The following is a description of a gene set: Any process that decreases the rate or extent of cholesterol storage. Cholesterol storage is the accumulation and maintenance in cells or tissues of cholesterol, cholest-5-en-3 beta-ol, the principal sterol of vertebrates and the precursor of many steroids, including bile acids and steroid hormones. Mouse Gene Set: GOBP_NEGATIVE_REGULATION_OF_CHOLESTEROL_STORAGE species: Mus musculus, and this is the list of marker genes: Pparg, Ces1g, Nr1h2, Ttc39b, Ces1b, Ces1a, Ppard, Ttc39d, Ppara, Ces1f, Nr1h3, Ces1d, Ces1c, Ces1e, Ces1h, Trem2